Given this list of marker genes LILRB4, EPX, SCGB1A1, LEF1, IFNL1, TNFRSF21, FOXP3, IFNA2, here is a description of the gene set: Any process that stops, prevents, or reduces the frequency, rate, or extent of interleukin-5 production. Human Gene Set: GOBP_NEGATIVE_REGULATION_OF_INTERLEUKIN_5_PRODUCTION studied in species Homo sapiens